The following is a description of a gene set: species: Mus musculus Any process that stops, prevents, or reduces the frequency, rate or extent of the regulated release of a catecholamine. Mouse Gene Set: GOBP_NEGATIVE_REGULATION_OF_CATECHOLAMINE_SECRETION, and this is the list of marker genes: Abat, Drd2, Crh, Ptgs1, P2ry1, Myo5a, Syt4, Entpd1, Cnr1, Chga, P2ry12, Ptger3, Gabbr1, Crhr1, Gck, Agtr2, Syt11, Ghsr, Crhr2